Given this list of marker genes ENTPD6, TRAF3IP2, SORL1, HMGN3 (high mobility group nucleosomal binding domain 3), DDIT4, SMAGP, ZFP36L2, CCDC57, RAB31, CCR7, UBA7, PLA2G4C, HBP1, COL14A1, KAT7, MCL1, H3C10, SOX4, SGK1, TUBB2A, MX1, EN2, NCAPD2, ICAM3, HGFAC, ITGA5, RASGRP2 (NCBI Gene Id 10235), TOB1, MTSS1 (MTSS I-BAR domain containing 1), MARCHF2, MYCNOS, ACAP1, GDPD5, ETHE1, RPL36A, TAFAZZIN, SERPINF1, VAMP5, MXRA8, PPP2R5D, DIO2, RNF139, JUND (JunD proto-oncogene, AP-1 transcription factor subunit), IFITM1, DOCK2, RPS28, CYFIP2, LFNG (LFNG O-fucosylpeptide 3-beta-N-acetylglucosaminyltransferase), SPTAN1, CIZ1, PBXIP1, DGKZ, RPL34, RPS8, PIAS3, ARRB2, LGALS8, HMGB2 (high mobility group box 2), CECR7, LGMN, BBLN, GPR6, CTSK, RPS20, VAMP1, DDIT3, MCF2L, FYB1, PIK3IP1, PLCD1 (NCBI Gene Id 5333), IL11RA, TRIB2, RGS1, MAPK11, FLOT2, TCF7, CASQ2, TMSB10, INS, TLE5, IDH2, TPM2, UTRN, DOP1B, H4C2, GPSM3, ITGA6, EYA2, RASA3, MRNIP (MRN complex interacting protein), S1PR4, ST3GAL1, DNAJB1, GCA, ID1, TRAF3IP3, PTK2B, CORO1A, SLCO2B1, FCGRT, LPAR2, SLC2A3, AIF1, CDC14A, CD302, LIMK2, BIN1, TNK2, SEC31B, VNN2, SIK1, H1-4, GADD45A, OCRL, H2BC14, TRADD, CTSO, JOSD1, ADA, MAP3K3, SIT1, ABLIM1, LAPTM5, SPOCK2, CDC25B, PAX6, KLF5, TRAM2, BICRAL, MFGE8, MAP4K2, BCL11A, DNAJB2, ACR, ARHGAP4, DPY19L1, LEPROTL1, IL7R, MAP3K9, RPS15A, CDC14B, ISG20, STK10, GIPC1, CADPS, KDM2A, CD247, SETD1B, SC5D, MICA, DLGAP1, DGKA, PPM1H, MAPRE3, PIM1, FAM168A, LGALS3BP, SYNE1, RDH5, LEPROT, DLG5, TXNIP, TRANK1, CYLD, SIPA1, CENPE, LITAF, PPARD, SELPLG, IFFO1, HHEX, IGBP1, MUC1, PPP6R2, DGCR2, TPX2, SEC14L2, FAM161A, PCDH7, RPS16, NINL, STK17A (NCBI Gene Id 9263), HPGD, PHKG2, VPS11, ABR (ABR activator of RhoGEF and GTPase), ARHGAP45, FTH1, CD37, RPS14, H1-10, ADD3 (adducin 3), ASIC3, SEPTIN9, TREX1, CXCR6, PHYH, MAN2B2, DNASE1L1, FOXO4, here is a description of the gene set: Microarray analysis was performed to determine the transcriptional profiles of NKT, CD1d-aGC+ Va24-, and CD4 T cells. Genes up-regulated in CD4 T cells: naïve versus activated. Human Gene Set: GSE28726_NAIVE_VS_ACTIVATED_CD4_TCELL_UP studied in species Homo sapiens from publication Constantinides MG, Picard D, Savage AK, Bendelac A (PMID 21632718)